The following is a description of a gene set: species: Homo sapiens Any process that modulates the size of a lysosome. Human Gene Set: GOBP_REGULATION_OF_LYSOSOME_SIZE, and this is the list of marker genes: BORCS6, BORCS7, BLOC1S1, SNAPIN, KXD1, BORCS5, BORCS8, KCNK6, BLOC1S2 (NCBI Gene Id 282991)